Given this list of marker genes Tpd52 (NCBI Gene Id 99538), Rassf2, Lag3, Egr1, Slamf8, Bap1 (Brca1 associated protein 1), St3gal1, Fzd7, Patz1, Fam20c, Ccl9, Sh2b3, Notch2, Gadd45g, Rara, Actb, Mtor, Fes, Laptm5, Zfp608, Ptprc, Gba1, Usp44, H2-M3, Ighg1, Hectd1, Spib, Spn, Tyrobp, Tnfaip6 (tumor necrosis factor alpha induced protein 6), Psen1, Ifnar2, Ifi207, Gm36723, Lrrk1, Clec4e, Tmem176b, Ccr6, Ctsl (cathepsin L), Sox12, Il6ra, Ccdc39, Pglyrp3, Cd8a, Ripk1, Sos2, Ndfip1, Rsad2, Il17c, Tcf3, Cox10, Jag2, Dll4, Lif, Jmjd6, Il1rl2, Apcs, Batf2, Tesc, Plcl2, Oscar, Adgrg3, Ascl2, Ifi213, Mir873a, Cldn18, Gpr18, Fos, Il7, Shb, Bax, Cebpg, Duxbl1, Plcb1, Tfe3, Syvn1, Tmem176a, Nhej1, Bcl2a1d, Ccr1l1 (NCBI Gene Id 12770), Ikzf3, Slc25a5 (solute carrier family 25 (mitochondrial carrier, adenine nucleotide translocator), member 5), Itgb3, Cd3g, Jak3, Mr1, Cr2, Muc19, Dusp10, Atm, Smad7, Pf4, Abl2, Ctsk, Hspb1, Zap70, Pla2g3, Qki, Tcf7, Hmgb1, Mfsd8, Vav1, Themis, Cd1d1, Pou2af1, Bad, Syk, Tet2, Pde1b, Crtam, Ikzf1, Drosha, Il4, Bak1, Nedd9, Nfkbiz, Fadd, Lef1, Ptcra, Mir19a, Smarcd2, Ctnnb1, Ankle1, Trf, Tspan2, Fanca, Rc3h2, Tnf, Pbx1, Tnfaip3, Itm2a, Klf10, Nfatc3, Dtx1, Lipa, Fbxw7, Gpr137b, Stat5b, Ms4a1, Ctla2a, Pir, Fam3c, Il10, Itgb6, Srp54a, Fgl2, Ifi206, Tmem178, Il17a, Prxl2a, Stat6, Nkap, Bcl2, Igkc, Mdk, Cd40lg, Il18r1, Fzd8, Hax1, Il1a, Vps13a (NCBI Gene Id 78932), Ctnnbip1, Pglyrp4, Hdac9, Irf4, Cd3d, Psmb11, Bcl11a, Foxp3, Prdm16, Ihh, Coa5 (cytochrome C oxidase assembly factor 5), Gmpr2, Ccr2, Gpr68, App, Traf6, Kctd9, Pknox1, Epsti1, Hs1bp3, Foxn1, Hells, Lilrb4a, Irf2bp2, Smarcd3, Il15, Stat3, Cd3e, Gpr89, Tsc1, Zbtb1, Mir17, Ccl3, Prdm1, Bmyc, Cdkn2a, Tescl, Zfpm1, Tbk1, Gata2, Atp7a, Cebpe, Il23a, Abl1, Pnp, Ifi209, Nfil3, Mmp14, Bbln, Batf, Pou4f2, Braf, Il1rl1, Gab3, Rnf41, Ltf, Rabl3, Epha2, Lep, Itpkb, Il7r, Creb1, Armc5, Tmem98, Tcirg1, Ubd, Aire, Mfng, Carmil2, Zbtb46, Fosl2, Prelid1, Dclre1c, Mettl3, Ceacam1, Adam17, Blm, Eeig1, Smarca4, Rag2, Tnfrsf11b, Hhex, Myb, Hmgb3, Prkdc, Rag1, Ndp, Malt1, Traj18, Eif2ak1, Iapp, Traf3ip2, Nrarp, Card11, Runx2, Enpp1, Gpr183, Gm11690, Atf2, Fasn, Bcl11b, Btk, Itk, Azi2, Il2ra, Erbb2, Plcg2, Ptpn22, Fancd2, Ddrgk1, Tlr4, Arid2, Scart2, Ptprj, Myd88 (myeloid differentiation primary response gene 88), Cd46, Top2b, Csf2, Cd4, Batf3, Kmt2a, Cmtm7, Xrcc4, Nrros, Ep300, Hotairm1, Zc3h12a, Cd81, Prex1, Car2, Zbtb7b, Tgfbr2, Hdac5, Actl6a, Rpl22, Sos1, Camk4, Runx1, Sp3, Cacnb4, Bcl6, Igtp, Zfp35, Xbp1, Cebpb, Stat5a, Pirb, Fshb, Sh3pxd2a, Slc9b2, Eomes, Cdk6, Fgfr3, Nme2, Trp53, Slamf9, Esrra, Mink1, Itgb8, Lgals9, Ifi203-ps (interferon activated gene 203, pseudogene), Slc39a7, Clec4g, Foxp1, Mir20a, Ucp2, Ap3d1, Hoxa7, Ift80, B2m, Mertk, Anxa1 (annexin A1), Farp2, Pou4f1, Il20, Cd27, Ocstamp, Stat4, Gli3, Zfp36l1, Onecut1, Srp54c, Ubash3b, Rhoh, Cracr2a, Ighm, Cflar, Irf1, Smarce1, Pafah1b1, Vsir, Cyld, Clpb, Tnfrsf11a, Mir301, Ptpn6, Socs1, Ptger4, Myh9, Large1, Sbno2, Ccr7, Gab2, Igkj5, Rptor, Chuk, Kat2a, Cd69, Rasgrp1, Hlx, Bmp4, Ly9, Clec2d, Dcaf1, Sema4a, Gimap5, Gata1, Tyro3, Lck, Tnfsf11, Il12a, Il36b, Tnfsf13b, Slc46a2, Pou1f1, H2-Oa, Zmiz1, Axl, Ccr1, Fcer1g, Lig4, Pglyrp2, Igsf23, Jagn1, Sash3, Slc4a2, Kdelr1, Tnfsf8, Ly6d, Lrrc8a, Txk, Kit, Hcls1, Il21, Trpm2, Inpp4b, Id2, Csf1, Nkx2-3, Ifi203, F2rl1, Evi2b, Anxa2, Entpd7, Inpp5d, Atg5, Dcstamp, Clec2g, Clec4d, Dnaja3, Lgals8, Ccr9, Cartpt, Cd79a (CD79A antigen (immunoglobulin-associated alpha)), Phf14, Kat7, Acin1, Il34, Sox4, Tusc2, Trib1, Cd83, Il27, Gps2, H2-DMa (histocompatibility 2, class II, locus DMa), Smarcb1, Itfg2, Atp11c, Il15ra, Wwp1, Il11ra1, Ager, Cd109, Fbxo7, Prkca, Pilrb1, Csf3, Mir150, Ahr, Mir18, Pla2g2d, Loxl3, Lrrc17, Siglec15, Lmbr1l, 6030468B19Rik, Actl6b, Irf8, Hdac7, Clec12a, Il18, Pcid2, Brd7, Mir223, Lilrb4b, Rora, Il2, Csf1r, Mafb, Tob2, Il25 (NCBI Gene Id 140806), Rb1, Pparg, Rorc, Phf10, Ptpn2, Ncaph2, Sco1, Klhl25 (NCBI Gene Id 76553), Dlk1, Prtn3, Tox, Gnas, Ror2, Pax1, Pou2f2, Sirt1, Ostm1, Mpzl2, Itgam, Hmga1 (high mobility group AT-hook 1), Naglu, Zc3h8, Clptm1, Cdh17, Thoc5, Hsf1, Bmp2, Kitl, Fut7, Psen2, Glo1, Skint1, Il9, Slamf6, Nfatc1, Il4i1, Smarcc2 (SWI/SNF related, matrix associated, actin dependent regulator of chromatin, subfamily c, member 2), Rras, Il5, L3mbtl3, Ifi214, Snx10, Chd7 (NCBI Gene Id 57137), Clec2i, Mir326, Nckap1l (NCBI Gene Id 78813), Il33, Dnajb9 (NCBI Gene Id 27362), Tfrc, Tshr, Prdx2, Prkcz (protein kinase C, zeta), Bmi1, Lgals1 (NCBI Gene Id 16852), Sox13, Calcr, Tlr2, Wnt4, Vegfa, Evi2, Lyl1 (NCBI Gene Id 17095), Wnt10b, Fshr, Smarca2, Vnn1, Adipoq, Gfi1b, Cd44, Nr3c1, Asxl2, Fzd5, Btnl6, Sart1, Msh2, Med1, Myc, Pglyrp1, Cbfb, Gata3, Cd74, Ap3b1, Il12b, C1qc, Zbtb7a, Fstl3, Casp8, Adam8, Smarcc1, Zeb1, Otud5, Arid1a, Adrm1, Nlrp3, Ctla4, Brd2, Gpc3, Gsk3b, Ppp3ca, Gimap1, Ada, Fbn1, Ncor1, Cbfa2t3, Ninj1, Dpp4, Il31ra, Rbpj, Rbp1, Nfam1, Cited2, Cyp26b1 (NCBI Gene Id 232174), Tgfb1, Satb1, Arid3c, Gon4l, Mef2c, Dock11, Fnip1, Srp54b, Mapk14, Gpr137, Ppargc1b, Trem2, Il1b, Lfng, Nme1, Erfe, Smarcd1, Mndal, Hsp90aa1, Pias3, Lepr, Ifng, Il4ra, Tmem64, Cd300lf, Ccn4, Brd4, Dhrs7b, Ppp2r3c, Pira12, Ccl20, Ifnb1, Tbx21, Srf, Lyn, Zfp36l2, Mir92-1, Il2rg, Btnl1, Cebpa, Gas6, Zfp609, Junb (jun B proto-oncogene), Gpr55, Lbr, Pbrm1, Ptk2b, Dock2, Ntrk1, Tnfsf18, Efna2, Ambra1, Gimap3, Kdm1a, Mir19b-1, Nfkbid, Tnfsf4, Pck1, Fzd9, Runx3, Il9r, Xrcc6, H2-Aa, Nf1, Pira1, Men1, Bcl3, Rps6, Cd28, Tjp2, Relb, Vps54, Kat5, Tmem131l, Ppp3cb, Il3, Ripk3, Ltbr, Opa1, Cd79b, Atp6ap1, Tlr9, Diaph3, Prr7, Itpripl1 (inositol 1,4,5-triphosphate receptor interacting protein-like 1), Rc3h1, Nfix, Flt3l, Rhoa, Mitf, Dock10, Src, Pik3r6, Sfrp1, Tnfsf9, Tespa1, Ighe, Cd24a, Kcnk18, Psap, Tcta, Ccl5 (NCBI Gene Id 20304), Cd101, Foxo3, Polm, Stk11, Tnfrsf9, Ccl19, Ezh2, Egr3, Socs5, Yy1, Btn2a2, Aqp8, Clcf1, Ifi208, Sh3rf1, Ireb2, Flt3, Il6, Fas, H2-Ea, Slamf1, Tal1 (T cell acute lymphocytic leukemia 1), Pik3r1, Cd19, Shh, Apc, Cul4a, Dicer1, Dll1, Ifnz, Ripk2, Foxj1, Jun, Zfp683, Spi1, Wnt1, here is a description of the gene set: Mouse Gene Set: GOBP_LEUKOCYTE_DIFFERENTIATION The process in which a relatively unspecialized hemopoietic precursor cell acquires the specialized features of a leukocyte. A leukocyte is an achromatic cell of the myeloid or lymphoid lineages capable of ameboid movement, found in blood or other tissue. species: Mus musculus